The following is a description of a gene set: The absolute number of B cells in the blood, per microlitre is above the upper limit of normal of the reference range for the appropriate sex and age-group. species: Homo sapiens Increased total B cell count Human Gene Set: HP_INCREASED_TOTAL_B_CELL_COUNT, and this is the list of marker genes: FAS, CARD11, FASLG, CASP10, NCKAP1L, LYN, PTPRC, NFKBIA, IKBKG, PRKCD, MAP3K14